The following is a description of a gene set: The UBA2:SAE1 complex catalyzes the formation of a thioester linkage between the C-terminal glycine of the mature SUMO and a cysteine residue (cysteine-173) in UBA2 (SAE2). During the process the C-terminal glycine residue of SUMO is reacted with ATP to yield pyrophosphate and a transient intermediate, SUMO adenylate. The SUMO adenylate then reacts with the thiol group of the cysteine residue of UBA2. Reactome Pathway: SUMO is conjugated to E1 (UBA2:SAE1) part of: Processing and activation of SUMO studied in species Homo sapiens, and this is the list of marker genes: SUMO2, SUMO1, SUMO3, SAE1, UBA2 (NCBI Gene Id 10054)